The following is a description of a gene set: Mouse Gene Set: chr4A5 species: Mus musculus, and this is the list of marker genes: Gm26881, Tmem8b, Galt (galactose-1-phosphate uridyl transferase), Vcp (valosin containing protein), Rusc2, Cimip2b, 4930556G01Rik, 4933428C19Rik, Gm26084, Ifnk, Gm11922, Gm26049, Cntfr, Spata31f1c, Gm12390, Bach2os, Ndufb6, Nfx1, Orc3, Rngtt, Smu1, Spaca1, Rigi, Fancg, Ccl27b, Gm12382, Il11ra2 (interleukin 11 receptor subunit alpha 2), Casp8ap2, Fam219a, Gm11930, Spmip6, Dnajb5, Gba2, Rmrp, Ccl21f, Gm12367, Topors, Gm12378, Gm21953, Hint2 (histidine triad nucleotide binding protein 2), Ccdc107, Gm12363, Kif24, Ccl19, Spink4, Gja10, Gm50471, Pm20d2, Cfap206, 4930509K18Rik, Gm12361, Ccl21d (NCBI Gene Id 65956), Phf24, Gm12370 (predicted gene 12370), Gm3893, Atosb, 4930578G10Rik, Psenen-ps, Taf9-ps, Spata31g1, Gm3883, Ccl19-ps1 (NCBI Gene Id 100861618), Ccl19-ps4, Ube2j1, Gm2163, Myorg, Unc13b, Gm12366, Tmem215, Gm25637, Gm12351, Rragd, Gm12387, Spata31f1b, Dcaf12, Dctn3, Gm20878, Arhgef39, Tln1, Zfp292, Gm25705, B4galt1, Gabrr1, Gm12472, 1700045I11Rik, Gm54215, Ccl27a, Mir873b (NCBI Gene Id 102465229), Aptx, Gm12384, Gm12375 (NCBI Gene Id 100417942), Gm12380, Ccl19-ps6, Gm50470, Srsf12, Mir5123, Lingo2, Nol6, Gm11941, Cnr1, Gm24837, Mdn1, Gm22732, Car9, Platr9, Enho, Aco1, Spata31f1a, Gm17167, Bach2it1, Aqp3, Gm3892, Gm10599, Ankrd6, Ube2r2, Dnaja1, Bach2, Gm12389, Gm12454, Gm22850, Il11ra1, Gm25623, Mir8118, Ccl19-ps3, Gm21586, Dnai1, Gm12383, Gm23709, Mir207, Gm12401, Gm52989, Gm24341, Pigo, 4933409K07Rik, Fam219aos, Ccl19-ps5, Cga, Gm12350, Gm136, Gm11920, Npr2, Il11ra3, Smim8, Gm12481, Gm11936, Rgp1, Gm11927, Ubap1, Map3k7, Aqp7, Ccl21e, Tpm2, Msmp, Gm12362, Gm26254, Chmp5, Gm12751, Ubap2, Gm12381 (NCBI Gene Id 102636968), Ccl27al, Gm12752, Gm13302, Rars2, Gm12369, Gm13303, C9orf72, Sigmar1, Gm21980, Gm22888, Gm17094, Mir876, Cd72 (CD72 antigen), Spata31f1d, Lyrm2, Gm12374, Gm12403, Smim27, Sit1, Tesk1, Gm25581 (NCBI Gene Id 115490042), Gm11942 (NCBI Gene Id 677215), Akirin2, Mir3094, Gm10601, Spata31f3, Gm23338, Gm12754, Ccl21a (C-C motif chemokine ligand 21 (serine)), Rpl23a-ps6, Gm23090, Creb3, Gm12404, Gm53189, Stoml2, Ccl21b, Gm11929, Gm12371, Pnrc1, Gm5859, Mir873a, 1700009N14Rik, Arid3c, Bag1, Gm12388, Gm17081, Gm12385, Gm12397, Nudt2, Slc35a1, Gm26087, Spag8, Gm13301, Atp8b5, Mob3b, Btf3-ps8, Rpp25l, Gabrr2, Fam221b, Gm23607, Gm12365, Gm25010, Gm11928